Given this list of marker genes Kcnmb2, Calm1, Kcnmb1, Stim1, Calm2, Kcnmb3, Kcnmb4, Calm3 (NCBI Gene Id 97428), Ryr2, Casr, Syt1, here is a description of the gene set: studied in species Mus musculus The series of events in which a calcium ion stimulus is received by a cell and converted into a molecular signal. Mouse Gene Set: GOBP_DETECTION_OF_CALCIUM_ION